Given this list of marker genes Tlr4, Oas1h, Mbp, Mcoln2, Oas1e, Tgfb1, F2rl1, Tirap, Lrp1, Ccl5, Cd74, Oas1g, Oas1f, Oas1a, Oas3 (NCBI Gene Id 246727), Klf4, Oas1d, Mif, Oas1b, Tnf, Foxp1, Hmgb1, Defb25, Postn, Lpl, Myd88, Ccn1, Oas1c, Map2k5, here is a description of the gene set: species: Mus musculus The appearance of chemokine (C-X-C motif) ligand 2 due to biosynthesis or secretion following a cellular stimulus, resulting in an increase in its intracellular or extracellular levels. Mouse Gene Set: GOBP_CHEMOKINE_C_X_C_MOTIF_LIGAND_2_PRODUCTION